Given this list of marker genes MICALL2, DLG5, PRKCH, CDH5, MPP7, MARVELD3, NPHP1, DLG1, CLDN6, RAMP2, NPHP4, OCLN, VCL, ECT2, RHOC, CLDN7, GRHL2, GPBAR1, MYO1C, SNAI2, PAK2, CLDN4, RAB13, CLDN18, CLDN19, CLDN10, OCEL1, CLDN15, CLDN23, GDF2, TBCD, CLDN17, PARD3, WDR1, IL17A, AFDN, IKBKB, DSG3, CLDN2 (claudin 2), ROCK2, SNAI1, CLDN34, FZD5, FBF1, ARL2, CTNNA1, ABI2, ESAM, CLDN8, CLDN22, EPHA2, CLDN20, APC, CLDN11, ACVRL1, PKN2, STRN, F11R, PECAM1, CLDN9, RAC1, MIR142, SLC39A9, WNT11, CLDN14, POF1B, PRKACA, RPS6, CLDN1, TJP1, CLDN25, CLDN3, CLDN5, MARVELD2, PDCD6IP, CLDN24, FRMPD2, CLDN16, TNF, ROCK1, MIR105-1, RHOA, SRF, here is a description of the gene set: studied in species Homo sapiens Human Gene Set: GOBP_APICAL_JUNCTION_ASSEMBLY The formation of an apical junction, a functional unit located near the cell apex at the points of contact between epithelial cells composed of the tight junction, the zonula adherens junction and the desmosomes, by the aggregation, arrangement and bonding together of its constituents.